The following is a description of a gene set: from publication Cui A, Huang T, Li S, Ma A, Pérez JL, Sander C, Keskin DB, Wu CJ, Fraenkel E, Hacohen N (PMID 38057668) Mouse Gene Set: CUI_MACROPHAGE_IFNA1_RESPONSE_DN Genes negatively differentially expressed in cell type: Macrophage upon treatment with cytokine: IFN-α1 in mouse lymph nodes in vivo. species: Mus musculus Cytokines mediate cell-cell communication in the immune system and represent important therapeutic targets. A myriad of studies have highlighted their central role in immune function, yet we lack a global view of the cellular responses of each immune cell type to each cytokine. To address this gap, the authors created the Immune Dictionary, a compendium of single-cell transcriptomic profiles of more than 17 immune cell types in response to each of 86 cytokines (>1,400 cytokine-cell type combinations) in mouse lymph nodes in vivo. A cytokine-centric view of the dictionary revealed that most cytokines induce highly cell-type-specific responses. For example, the inflammatory cytokine interleukin-1β induces distinct gene programmes in almost every cell type. A cell-type-centric view of the dictionary identified more than 66 cytokine-driven cellular polarization states across immune cell types, including previously uncharacterized states such as an interleukin-18-induced polyfunctional natural killer cell state., and this is the list of marker genes: Ybx1, Ftl1 (NCBI Gene Id 14325), Mapk14, Eef1a1, Use1, Kctd12, Lyz1, Mt1, Calm2, Eef2, Cox7a2l, Ptp4a3